Given this list of marker genes Pdha2, Ache, Pemt, Chat, Chka, Pdha1, Pcyt1a, here is a description of the gene set: species: Mus musculus Mouse Gene Set: WP_ACETYLCHOLINE_SYNTHESIS Acetylcholine synthesis